Given this list of marker genes CDC37, GBA1, HK2, PRKN, VDAC1, HDAC6, ATP5IF1, TOMM7, VPS13C, HUWE1, HTRA2, MFN2, PINK1, OPTN, TIMM23, MUL1, here is a description of the gene set: Human Gene Set: GOBP_TYPE_2_MITOPHAGY species: Homo sapiens The selective autophagy process in which a mitochondrion is degraded by macroautophagy in a process initiated by mitochondrial depolarization (mtDepo) followed by Parkin binding, and ubiquitination of outer membrane proteins, to remove potentially harm-inducing dysfunctional/damaged mitochondria.